The following is a description of a gene set: Reactome Pathway: Defective GCK causes maturity-onset diabetes of the young 2 (MODY2) part of: SLC transporter disorders Cytosolic glucokinase (GCK) (and three isoforms of hexokinase) catalyse the irreversible reaction of alpha-D-glucose (Glc) and ATP to form alpha-D-glucose-6-phosphate (G6P) and ADP, the first step in glycolysis. In the body, GCK is found only in hepatocytes and pancreatic beta cells. GCK and the hexokinase enzymes differ in that GCK has a higher Km than the hexokinases and is less readily inhibited by the reaction product. As a result, GCK should be inactive in the fasting state when glucose concentrations are low but in the fed state should have an activity proportional to glucose concentration. These features are thought to enable efficient glucose uptake and retention in the liver, and to function as a sensor of glucose concentration coupled to insulin release in pancreatic beta cells. Defects in GCK are can cause maturity-onset diabetes of the young 2 (MODY2; MIM:125851), a heritable early onset form of type II diabetes. studied in species Homo sapiens, and this is the list of marker genes: GCK